The following is a description of a gene set: species: Homo sapiens from publication Zhang W, Ferguson J, Ng SM, Hui K, Goh G, Lin A, Esplugues E, Flavell RA, Abraham C, Zhao H, Cho JH (PMID 22715389) Genes down-regulated in CD4 Th17 T cells: enriched versus negative. In this study, we examined differential gene expression in naïve human CD4+ T cells, as well as in effector Th1, Th17-negative and Th17-enriched CD4- T cell subsets. We observed a marked enrichment for increased gene expression in effector CD4+ T cells compared to naive CD4+ among immune-mediated disease oci genes. Within effector T cells, expression of disease-associated genes was increased in Th17-enriched compared to Th17-negative cells. We used microarray to examine the gene expresssion profile and level of human naïve, Th1 and effector T cell subsets. Human Gene Set: GSE32901_TH17_EMRICHED_VS_TH17_NEG_CD4_TCELL_DN, and this is the list of marker genes: KCNJ2, PLIN2, NEIL1, PIK3C3, JOSD2, HCLS1, CISD2 (CDGSH iron sulfur domain 2), SCAI, PPP2R5E, SPO11, FAM107B, FAM78A, GVINP1, ABTB2, DNAJC25, TMEM35A, ACSS2, HIF1A (NCBI Gene Id 3091), AGK, MOSPD2, ACVR2A, NISCH, NFKB1, GLIS3, SUMF1, RNF125, SMCHD1, IRF9, DENND4C, AIP, PTPN22, EHHADH (enoyl-CoA hydratase and 3-hydroxyacyl CoA dehydrogenase), GABPA, ARV1, HAPLN1 (hyaluronan and proteoglycan link protein 1), FBXL20, NFKBIA, SLC12A4, PDE2A, SELENOP, RAD51D, NEK7, YPEL2, NPLOC4, GTF2I (general transcription factor IIi, NCBI Gene Id 90875), ABCG2, FGFR1OP2, PNPLA7, SPATA13, HPS1, IFIH1, TRABD (TraB domain containing, NCBI Gene Id 80305), SHARPIN, PREB, RIC8B, FHIP1B, ST8SIA1, OTUB1, RUNDC3B, FBXL6, BLMH, NDE1, TXNIP, HDAC6, ROCK2, RTP4, RTN4, ZFP36, NSD3, DGAT1, ABCC5, HLTF, NIPAL3, CLASRP, MYO3B, KCTD2, ABI1, VPS37B, CPSF4, ARAP1, PDLIM5, SLC52A1, MIEF2, AMH, BZW2, SNTB1, CHD2, MLST8, PPFIBP1, LRRC51, CYTIP, FBXL12, ATPAF1, BCL6, CENPQ, ATXN10, SIN3B, CFAP144P1, CAMK2D, EPC2, ANKRD50, SKAP1, HACE1, CD40LG, TCP11L2, SLC12A7, RANBP9, CHST15, COIL, ABHD2, PANX1, NDRG3, AFTPH, IL17RA (interleukin 17 receptor A), SLA, CAMK1D, CCPG1, TTC32, KIF3A, TNFAIP3, ABCB9, DHX30, WRN, IP6K2, HS2ST1, ACAA2, RASSF7, DNAJB13, TRAF1, DNAJB1, PARP11, MAP2K6, ASB8, ACSS1, GTF2IRD2, ALS2CL, NAPG, LPAR3, PDE3B, SERINC5, DMAP1, PPP2R2A, ECH1, ZFP69, EGLN1, MIEF1, TMEM43, TRIM33, FOXO4, SLAIN1, TOM1, MIR421, CTSA, RRAGA, PDE7A, SMAD7, ACADL, SLC26A11, KHNYN, NFKBIZ, BCL7B (BAF chromatin remodeling complex subunit BCL7B), UNKL (NCBI Gene Id 65259), PLK2, OTUD1, FAM83F, SLC27A2 (solute carrier family 27 member 2), DIP2A, ARHGAP9, DENND6B (DENN domain containing 6B), SMARCD2 (SWI/SNF related, matrix associated, actin dependent regulator of chromatin, subfamily d, member 2), RAB8A, AP5M1, PRKCQ, GRAMD2B